The following is a description of a gene set: studied in species Mus musculus from publication Chen Y, Wang X (PMID 31504780) Genes predicted to be targets of miRBase v22 microRNA mmu_miR_6945_5p in miRDB v6.0 with MirTarget v4 prediction scores > 80 (high confidence targets). Mouse Gene Set: MIR_6945_5P, and this is the list of marker genes: Rhbdl3, Tafa3, Adra2b, Ahcyl2, Fam168a, Chrm1, Phf24, Hycc2, Adam1b, Nfatc2, Bbs1, Adal, Zfp365, Bend3 (NCBI Gene Id 331623), Slc17a7, Csnk1g1, Plcb2 (phospholipase C, beta 2, NCBI Gene Id 99018), Tspan15, Col4a4 (NCBI Gene Id 319847), Btaf1, Atosb, Nrf1, Ube2e1 (NCBI Gene Id 22194), Vps39 (NCBI Gene Id 269338), Fam20a, Tanc2, Pip4k2b, Arrb1, Col4a5, Ppp2r3d (protein phosphatase 2 (formerly 2A), regulatory subunit B'', delta), Sema3f, Zfp830, Znrf3, Dkk3, Ankrd54, Ccdc92b, Samhd1, Ssbp2, Ceacam12, Clip3, Hcar1 (NCBI Gene Id 243270), Rac3, C2cd4c, Pus1, Atxn7l3, Nutf2, Heyl, Itsn1, Mnt, Slain2, Washc4, Man1b1, Fam53c, Smpd3, Dlgap3, Rrp7a, Tek, Lrrc56, Khdrbs1, Gpr165, Csrnp2, S1pr3, Akirin2, Zfp780b, Tppp, Sdc3, E130308A19Rik (NCBI Gene Id 381529), Bcl9, Glyctk, Csf1, Nacc1, Rab43, Btrc, Btf3l4, Icmt, Slc25a39 (NCBI Gene Id 68066), Cyp2c68, Hgh1, Gata4, Stk4, Fbxl20, Tom1l2, Kdm3b, Pnma8b, Raly, St3gal1, Nxph3, Ntsr1, Col9a1, Kif3b, Ccdc127, Kcne4, Rce1, Rnf216, Slc22a27, Rcan2 (regulator of calcineurin 2), Lrrc8a, Tmem104, Celsr2, Aifm3, Rpp14, Alpl, Hs3st3b1, Hip1, Dkk1, Slc22a29, Tmem167, Mtor, Exoc8, Kbtbd2, Casr, Dll3, Tnfsf4, 2510039O18Rik, Pclo, Scara3, Mtf1, Tmem270, Ssc4d, Elac1, Dcaf8, Myadml2, H2-Oa, Rab3d, Setd1b, Tirap, C2cd2l, Ccdc40, Trim35, Sulf1, Lad1, Myocd, Pou6f1, Ifit1, Trim67, Spag5, Cttn, Foxj1, Desi1, Dtx1, Exd2 (NCBI Gene Id 97827), Ldlrap1, Wnt5a, Ezh1, Tmem253, Psenen, Btg2, Rcor1, Rnf111, Smim3, Phaf1, Oxsr1, Scmh1, Amer3, Cd34, Zmym3, Dvl3, Gdap2, Krtap9-3, Scube1, Itpr3, Fam131b, Ypel5, Abhd5, Trim44, Mymk, Sgpp2, Cnot9, Phlda1, Hpcal4, Serpina12, Gata2, Ammecr1, Celsr3, Sec24c, Zbtb46, Usf2, Shisa7, Ephb3, Dagla, Add2, Extl3, Tmtc3, Sox10, Ciao1, Hsd17b8, Mtx1, Bysl